Given this list of marker genes PHOX2A, TCTN1, CLN8, LHX4, LHX3, here is a description of the gene set: The process in which neuroepithelial cells in the neural tube acquire specialized structural and/or functional features of somatic motor neurons. Somatic motor neurons innervate skeletal muscle targets and are responsible for transmission of motor impulses from the brain to the periphery. Differentiation includes the processes involved in commitment of a cell to a specific fate. species: Homo sapiens Human Gene Set: GOBP_SOMATIC_MOTOR_NEURON_DIFFERENTIATION